Given this list of marker genes PEX6, LAMB3, SCN2A, KCNA1, HNF1B, SIK1, PNKP, PIGQ, ARX (aristaless related homeobox), ITGB4, LAMC2, SCN1B, GRM7, MAPRE2, LAMA3, TRIM8, CASK, DMXL2, PLEC, LHX1, GRIN1, NEUROD2, SLC32A1, GNAO1, SLC25A22, CDKL5, PIGP, TP63, ITGA6, here is a description of the gene set: Ureterocele Human Gene Set: HP_URETEROCELE A ureterocele is a congenital saccular dilatation of the distal segment of the ureter. studied in species Homo sapiens